Given this list of marker genes NDN, OCA2, TBCK, BRAF, SNRPN, CDH23, GLI3, RBM28, TBX19, NFKB2, AAAS, MAGEL2, IARS2, CTNNB1, POMC, AIP (aryl hydrocarbon receptor interacting protein), MEN1, PCSK1, here is a description of the gene set: species: Homo sapiens Central adrenal insufficiency A form of adrenal insufficiency related to a lack of ACTH, which leads to a decrease in the production of cortisol by the adrenal glands. Aldosterone production is not usually affected. Human Gene Set: HP_CENTRAL_ADRENAL_INSUFFICIENCY